The following is a description of a gene set: from publication Schaefer CF, Anthony K, Krupa S, Buchoff J, Day M, Hannay T, Buetow KH (PMID 18832364) Human Gene Set: PID_IL6_7_PATHWAY studied in species Homo sapiens IL6-mediated signaling events, and this is the list of marker genes: FGG, GAB1, IL6, LBP, IL6ST, MAPK14, MYC, A2M, MITF, JUNB, STAT1, PIK3R1, VAV1, IRF1, GAB2, TNFSF11, FOXO1, LMO4, MCL1, MAP2K6, PTPRE, PRKCD, PIAS1, JUN, JAK1, FOS, SOCS3, HCK, TIMP1, PTPN11, SOS1, JAK2, CEBPD, IL6R, CEBPB, TYK2, RAC1, PIAS3, MAPK11, CRP, HSP90B1, GRB2, PIK3CA, STAT3, MAP2K4, BCL2L1, AKT1